The following is a description of a gene set: Testosterone biosynthesis. Pathway ID: N01541. Pathway type: Reference. Pathway class: nt06019 Steroid hormone biosynthesis. Human Gene Set: KEGG_MEDICUS_REFERENCE_TESTOSTERONE_BIOSYNTHESIS species: Homo sapiens Pathway Definition from KEGG: Pregnenolone -- CYP17A1 >> HSD3B1/2 -> Androstenedione -- (AKR1C3,HSD17B) -> T -- SRD5A -> DHT, and this is the list of marker genes: HSD3B1, HSD17B8, SRD5A2, AKR1C3, CYP17A1, HSD17B2, HSD17B3 (NCBI Gene Id 3293), HSD3B2, SRD5A1, SRD5A3, HSD17B6